The following is a description of a gene set: from publication Cui A, Huang T, Li S, Ma A, Pérez JL, Sander C, Keskin DB, Wu CJ, Fraenkel E, Hacohen N (PMID 38057668) Genes positively differentially expressed in cell type: ILC (innate lymphoid cell) upon treatment with cytokine: IL-23 in mouse lymph nodes in vivo. studied in species Mus musculus Mouse Gene Set: CUI_ILC_IL23_RESPONSE_UP Cytokines mediate cell-cell communication in the immune system and represent important therapeutic targets. A myriad of studies have highlighted their central role in immune function, yet we lack a global view of the cellular responses of each immune cell type to each cytokine. To address this gap, the authors created the Immune Dictionary, a compendium of single-cell transcriptomic profiles of more than 17 immune cell types in response to each of 86 cytokines (>1,400 cytokine-cell type combinations) in mouse lymph nodes in vivo. A cytokine-centric view of the dictionary revealed that most cytokines induce highly cell-type-specific responses. For example, the inflammatory cytokine interleukin-1β induces distinct gene programmes in almost every cell type. A cell-type-centric view of the dictionary identified more than 66 cytokine-driven cellular polarization states across immune cell types, including previously uncharacterized states such as an interleukin-18-induced polyfunctional natural killer cell state., and this is the list of marker genes: Galnt17, Nudt22, Ptpn3, Map3k7, Mrps11, Lrrc8c, Card19, Lars1, Rnf181, Ublcp1, Spsb1, Dbf4 (NCBI Gene Id 27214), Zfp35, Nxt2, Atp2b4, Setbp1